Given this list of marker genes SFXN1, TFDP2, GPI, POLR3D, DGKA, KIF5C, CLSPN, ENTREP3, RASA3, RPL35A, PMAIP1, MYH10, PIP5K1A, STMN1, ASF1B, SYNE3, DUSP12, CD244, CYTIP, ERH, DNAH6, CEP131, CAV1, PRPF4, CTCF, NFYC, PPP1R2, EIF2B3, KNTC1, PAFAH1B3, ANGPT1 (NCBI Gene Id 284), BHLHE40, GFUS, NAA35, AQP8, MYG1, SRP54, IFI35 (interferon induced protein 35), DNAJC7, TUBB, KIF23, PXMP2, POLD3, HMMR, CXXC1, U2AF1, GOLT1B (golgi transport 1B), HMGB3P1, HSF2, SLC5A6, ASNSD1, GAD2, CDR2, FUS, NSUN5, SYNGR3, ISG20, ALDH18A1, BCL7C, WDR6, FLOT1 (flotillin 1), ABT1, ATP8B4, PRR14, PPP6R2, DENND1C, CD28, RNF4, CDCA4, TAF5, GK2 (glycerol kinase 2), DEF6, ITK, AKAP12, GTF2A1, KDELR2, PPP3CC, SERPINB1, SLC7A5, TLK2, SRSF7, RPL11, DNAJA3, CD247, ORC1, MED20, RHOT2, GUCY1B1, PQBP1, CLIC1, PPP1R8, GINS4, NFKBIB, ANKHD1, BTG3, HIRIP3, SRSF6 (NCBI Gene Id 6431), KCNA1, F2RL1, GOLGA8A (NCBI Gene Id 23015), CHSY1, IER2, SH2D3C (SH2 domain containing 3C), LTB, PIM2, GZMM, EZR, ZBTB17, TK1, PDGFA, SMAD3, IL10, RRM1, NCAPG2, SNRPA, ASH1L, ARL3, IDH3G, FKBPL, NR6A1, TAP2, GNA14, PRC1, STOML1, PERP, TRAF5, CA6, KLHDC8A, CSNK1G1, ITGA10, SNRPA1, BCOR, ERAP2, NUP155, IGSF9B, HSPA2, TMEM131L (transmembrane 131 like), BMAL2, BIRC5, HTR6, EIF2AK1, CDC123, EOLA2, IPCEF1, PKMYT1, NPRL2, NSUN5P2, USP36, PRDM2, SAMSN1 (SAM domain, SH3 domain and nuclear localization signals 1), SLC22A1, DGCR8, KHDC1L, SNRPB, TFR2, LMBR1L, GTF2H4, HSD11B1, XRCC2, TIMELESS, KCNK1, SUCO, EIF5B, PTBP3, PDP1, GK3, CNN2, DDX43, HMBS, H1-3, IL26, PITPNM1, PRDX3, AQR, IGFLR1, BST2, ZWILCH, TRAC, CRLF3, LAX1, SSR2, ODF2, ZDHHC13, CSE1L, TIA1, BECN1, EED, DMWD, POLR2I, SLC13A1, WDR82, NUSAP1, EVC, PDK3, PRB3, RBCK1, BRF2, FUBP1, ERCC2, here is a description of the gene set: from publication Jeffrey KL, Brummer T, Rolph MS, Liu SM, Callejas NA, Grumont RJ, Gillieron C, Mackay F, Grey S, Camps M, Rommel C, Gerondakis SD, Mackay CR (PMID 16474395) Human Gene Set: GSE3982_MAC_VS_TH1_DN Genes down-regulated in comparison of macrophages versus Th1 cells. studied in species Homo sapiens In the present study we used Affymetrix oligonucleotide microarrays to produce gene transcription profiles for the major leukocyte types in humans. This comprehensive dataset enabled us to not only establish which genes were expressed in each leukocyte type, but also which genes were expressed in each subset after activation. The used of a comprehensive dataset of gene profiles from all the major human leukocyte subsets enabled a novel and powerful means for identification of genes associated with single leukocyte subsets, or different immune paradigms.